Given this list of marker genes CELF6, NNAT (NCBI Gene Id 4826), TMEM183A, ARRDC3, ERI3, PURB, USF2, SYNGAP1, CNNM4, FLT1, ARHGAP36, CTIF (NCBI Gene Id 9811), HNRNPA1, EPHA4, ADGRL1, PAPPA, VAT1 (NCBI Gene Id 10493), UNC5C, SHISA7, HNRNPK, KLF11, KDM5B, PPP6R2, CNOT6, MYO1C, ATXN2L, NFASC (neurofascin), MAP3K7, VCP, MAPRE1, NXPH1, ACP4, NHERF1, RASSF1, GRM3, ABLIM2, PAFAH1B1, DNAJC7, CDIP1, HNRNPA1L2, WDR81, KCNMA1, BLCAP, TRPC3, HAP1, C3orf18, CDK14, NACC1, CYTH1, POMT2, NOVA1 (NCBI Gene Id 4857), BCL6, PODXL, EMILIN2, USP8, UBE3A, THRA, SGCD, EMX2, CTDSPL, ANKZF1, NRXN1 (NCBI Gene Id 9378), PLEKHH3, PPP6R3, FHL1, SLC4A10, ARHGAP29, here is a description of the gene set: Genes having at least one occurence of the motif GACAGGG in their 3' untranslated region. The motif represents putative target (that is, seed match) of human mature miRNA hsa-miR-339 (v7.1 miRBase). species: Homo sapiens Human Gene Set: GACAGGG_MIR339